The following is a description of a gene set: species: Mus musculus The chemical reactions and pathways resulting in the breakdown of adenosine, adenine riboside, a ribonucleoside found widely distributed in cells of every type as the free nucleoside and in combination in nucleic acids and various nucleoside coenzymes. Mouse Gene Set: GOBP_ADENOSINE_CATABOLIC_PROCESS, and this is the list of marker genes: Pnp, Adal, Uox, Ada, Urad (NCBI Gene Id 631440, ureidoimidazoline (2-oxo-4-hydroxy-4-carboxy-5) decarboxylase), Urah, Xdh